Given this list of marker genes MVD, PMVK, RECQL4, FDPS, SLC17A9, RNU12, ANAPC1, MVK, here is a description of the gene set: Human Gene Set: HP_POROKERATOSIS A clonal disorder of keratinization with one or multiple atrophic patches surrounded by a clinically and histologically distinctive hyperkeratotic ridgelike border called the cornoid lamella. Porokeratosis species: Homo sapiens